The following is a description of a gene set: studied in species Mus musculus Mouse Gene Set: GOBP_CELLULAR_RESPONSE_TO_PARATHYROID_HORMONE_STIMULUS Any process that results in a change in state or activity of a cell (in terms of movement, secretion, enzyme production, gene expression, etc.) as a result of a parathyroid hormone stimulus., and this is the list of marker genes: Kat2b (K(lysine) acetyltransferase 2B), Phex, Hdac6, Fos, Wnt10b, Mef2c, Sost, Fgf23, Gja1, Prkaca